Given this list of marker genes H2ac6, H2ac12 (H2A clustered histone 12), Zfp987, H2bc27, H4c8, H2bc22, Zfp990, Zfp994, H4c1, H2ac10, Zfp758, Zfp942, H3c2, H3c4, H2ac15, AU041133, H2ac20, H4c2, H2bc9, H4c6, H2ac4, Zfp874b, Zfp995, Zfp947, H2ac23, H3c15, H3c1, H2bc11 (NCBI Gene Id 319183), H4c12, H2bc12, Zfp454, H2bc15, H2ac1, H2bc1, H3c13, Zfp383, H2ac19, H2ac8, Zfp354a, Gm4924 (NCBI Gene Id 237412), H4c11, Gm7072, H2az2, H4c18, H3c10, Zfp317, H4c3, H4c14, H2ac22, H2ac11, Zfp946, Zfp982, Gm5141, Zfp989, H2ac13, H4c9, H4c17, Zfp677, Zfp324 (zinc finger protein 324), Zfp971, Zfp992, AI987944, Zfp141, Zfp943, H2bc8 (H2B clustered histone 8), H2ac7, H3c6, Gm45871, Zfp119b, Gm14325, H3c11, H2ac24, Zfp872, Gm14391, H3c3, Gm10033, H3c7, H4c4, B020011L13Rik, H2ax, H2bc13, Zfp991, H2bc7, H3f3a, Zfp934, H2bc3, H3c8, here is a description of the gene set: part of: Epigenetic regulation of gene expression This event has been computationally inferred from an event that has been demonstrated in another species.<p>The inference is based on the homology mapping from PANTHER. Briefly, reactions for which all involved PhysicalEntities (in input, output and catalyst) have a mapped orthologue/paralogue (for complexes at least 75% of components must have a mapping) are inferred to the other species. studied in species Mus musculus Reactome Pathway: Regulation of endogenous retroelements electronically inferred by orthology from the curated human pathway